The following is a description of a gene set: Any process that activates or increases the frequency, rate or extent of artery morphogenesis. studied in species Homo sapiens Human Gene Set: GOBP_POSITIVE_REGULATION_OF_ARTERY_MORPHOGENESIS, and this is the list of marker genes: NFATC3, EDN1, RTN4, AKT3, NOTCH1, EFNB2, MDK